The following is a description of a gene set: The chemical reactions and pathways involving tetrapyrroles, natural pigments containing four pyrrole rings joined by one-carbon units linking position 2 of one pyrrole ring to position 5 of the next. species: Mus musculus Mouse Gene Set: GOBP_TETRAPYRROLE_METABOLIC_PROCESS, and this is the list of marker genes: Mmachc, Blvrb, Iba57, Cox10, Mmab, Sptb, Spta1, Mtrr, Hmbs, Cyp1a2, Pgrmc1, Ugt1a1, Bdh2, Tmem14a, Slco1b2, Hmox1, Abcd4, Hpx, Abcb6, Cyp1a1, Amn, Urod, Alas1, Fxn, Cpox, Slc25a39, Slc6a9, Cubn, Fech, Clybl (NCBI Gene Id 76264), Srrd, Cox15, Tmem14c, Alas2, Blvra, Cyp2a5, Abcb10, Snx3, Atp5if1, Eif2ak1, Slc48a1, Alad, Mmaa, Hmox2, Uros, Mtr, Mmadhc, Hnf1a, Slc11a2, Cyb5r4, Ank1, Hebp1, Slco1a6, Rsad1, Abcb7, Ppox, Ireb2